The following is a description of a gene set: Human Gene Set: GOBP_ENDOCARDIAL_CUSHION_FORMATION The developmental process pertaining to the initial formation of an endocardial cushion. The endocardial cushion is a specialized region of mesenchymal cells that will give rise to the heart septa and valves. studied in species Homo sapiens, and this is the list of marker genes: BMP7, MSX2, TMEM100, DCHS1, FGF8, TGFBR1, TGFB3, HEY2, ACVR1, TBX2, TBX20, NOG, ENG (endoglin), TGFB2 (NCBI Gene Id 7042), APLNR, ROBO2, SMAD4, SNAI2, TGFB1, BMPR1A, SNAI1, ROBO1, HEYL, BMP5, BMP2, RBPJ, TGFBR2, MSX1, NOTCH1, TBX3, BMP4 (bone morphogenetic protein 4)